The following is a description of a gene set: studied in species Homo sapiens Nuclear receptors (NRs) are ligand-activated transcription factors that bind to small lipid based molecules to regulate gene expression and other cellular process. This family includes receptors for steroid hormones and derivatives (such as estrogen, progesterone, glucocorticoids, Vitamin D, oxysterols and bile acids, among others) as well as receptors for retinoic acids, thyroid hormones and fatty acids and their derivatives. These ligands are able to diffuse directly through cellular membranes as a result of their lipophilic nature. The 48 human nuclear receptors share a conserved modular structure that consists of a sequence specific DNA-binding domain and a ligand-binding domain, in addition to various other protein-protein interaction domains. Upon interaction with ligand, NRs bind to the regulatory regions of target genes as homo- or heterodimers, or more rarely, as monomers. At the promoter, NRs interact with other activators and repressors to regulate gene expression (reviewed Beato et al, 1996; Simons et al, 2014; Hah and Kraus, 2010). A number of nuclear receptors are cytoplasmic in the absence of ligand and exist as part of a heat shock protein complex that regulates their cellular location, protein stability, competency to bind steroid hormones and transcriptional activity. Ligand-binding to these receptors promotes dimerization and nuclear translocation. Other nuclear receptors are contstitutively nuclear and their chromatin-modifying activities are regulated by ligand binding. In addition to the classic transcriptional response, NRs also have a role in rapid, non-nuclear signaling originating from receptors localized at the plasma membrane. Ligand-binding to these receptors intitiates downstream phospholipase- and kinase-based signaling cascades. Signaling by estrogen, liver X and retinoic acid receptors are currently described here. part of: Signal Transduction Reactome Pathway: Signaling by Nuclear Receptors, and this is the list of marker genes: NCOA1, ABCG8, RARB, H2BC26, GNAI3, DDX5, ALDH8A1, GNAT3, PPID, GNB4, H2BC12L, PLTP, H2AZ2, APOC1, RDH11, H2AC6 (NCBI Gene Id 8334), MIR26A1, DHRS4, AXIN1, APOC2, CHD1 (NCBI Gene Id 1105), AGO4, ATF2, SDR16C5, ALDH1A3, S1PR3, RDH16, BCL2, H2BC21, SHC1, NCOA3, H3-3A, NOS3, EGFR, ALDH1A1, MIR33B, CCND1, CDKN1B, GNG13, CDK9 (NCBI Gene Id 1025), EREG, KRAS, SP1, H2AC4, GNG3, H2BC4, RARG, RAD21 (RAD21 cohesin complex component), CTSD, ABCA1, TLE3, POU2F1, ABCG5, H2AC20, H2BC13, GNB2, NCOA2, CCNT1, KDM4A, GNG8, RXRG, RXRB, H2BC14, RDH14, USF2, CRABP1, AKR1C3, GNG10, APOE, CREBBP, PGR, GNG11, KCTD6, MOV10, H2AB1, AGO3, RDH5 (retinol dehydrogenase 5), POLR2L, AGO1, PDK1, CYP26C1 (NCBI Gene Id 340665), H2BC9, POLR2C, GATA3, H2AJ, NRIP1, GNG5, GNG12, PRKCZ, STRN, SCD, POLR2B, CXCL12, ARL4C, GPAM, HSP90AB1, FOSB, MAPK1, PDHA2, HRAS, MIR26A2 (NCBI Gene Id 407016), TFF1, EGF, GTF2F1, GNB1, EBAG9 (NCBI Gene Id 9166), ADH1C, CALM1, H2BC17, GNG2 (NCBI Gene Id 54331), H2BC3 (H2B clustered histone 3), ALDH1A2, DLAT, TGFA, GNAI2, CAV2, DHRS3, IGF1R, FABP5, DHRS9, MED1, PTGES3, NCOR2, JUND, MYC, ADH4, POLR2A, CXXC5, PDK4, POLR2J, NR5A2, GPS2, PDHA1, PPP5C, TBL1XR1, FKBP4, PDHB, CBFB, ZDHHC7, SRF, NR1H3, PTK2, RDH13, USF1, ANGPTL3 (NCBI Gene Id 54222), EPGN, CYP26A1, TNRC6B, SMC3, GTF2A2, STAG2, TBP, ADH1A, NCOR1, BTC, PIK3R3, MYB, GNB5, PIK3R2, STAG1, FOXO3, EEPD1, AREG, ZNF217, MIR33A, POLR2F, AKT2, ABCG1, SPHK1, KANK1, EP300, FOS (Fos proto-oncogene, AP-1 transcription factor subunit), GNG7, GTF2A1, RXRA, CRABP2, PIK3CA, GNG4, SREBF1, APOC4, SMC1A, HDAC3, KDM3A, JUN, H2BC15, KAT5 (lysine acetyltransferase 5), H2AC18, SRC, TNRC6A, UHMK1, PDPK1, XPO1, H2BC5, PDK2, GNGT2, POLR2D, PDK3, H3C15, TNRC6C, CREB1, PCK1, MAPK3, MMP7, AGO2, POLR2G, MMP3, PPARD, YY1 (NCBI Gene Id 7528), PIK3R1, AKT1, MMP2, PRMT1, GNB3, POLR2I, KAT2B, KDM4B, KDM1A, MYLIP, GREB1, H2BC12, MMP9, GTF2F2, FABP6, KDM1B, UGT1A3, ESR1, MIR144, ELK1 (NCBI Gene Id 2002), POLR2H, PLIN1, HBEGF, NRAS, H3C1, RDH10, H4C1, H2AC14, ZDHHC21, CAV1, TFF3, FKBP5, CETP, HSP90AA1, POLR2K, PDHX, KPNA2, ESR2, GNAI1, TBL1X, RUNX1, CITED1, POLR2E, H2BC1, H2BC11, CYP26B1, DLD, H2AC7, CARM1, RARA, MIR26B, AKT3, HSPB1, GNGT1, ERBB4, APOD, MIR613, FOXA1, FASN, HDAC1, H2AX, NR1H2